Given this list of marker genes PPP1CB, GPC6, WRAP73, LGI2, ACAN, KIF5C, MBNL3 (muscleblind like splicing regulator 3), OLFM3, PITPNC1, GALNT16, NAB1, DIO2, ZNF208, FERRY3, SATB2, SLC23A3, STAC, CCND2, ZNF704, RIGI, PISD (NCBI Gene Id 29838), ADCY7, RREB1, VEZF1, EPB41L1, KLHDC7A, SLC25A30, CSF2RB, GRM5, FYN, DYRK1A, FAXC, IKZF4, ACOT13, RCOR3, ZBTB34, EYA4, PDE5A, ATP1B4, TBC1D8, NECTIN1 (NCBI Gene Id 84853), STXBP4, KLKB1, TMEM108, ZBTB20, MAP7, TDRD6, DNAJC6, PLXNA4, CEP350, ETV5, PIK3C2A, ARHGAP5, TMPO, TAF4, SCAI, SKAP2, PRDM1, XKR4, CAMK1G, PTPRB, CACNA1G, ADAMTS3, MECP2, CNTN4, CTNNA3, SERPINE2, ZNF117, ANKRD27 (NCBI Gene Id 84079), ADGRG2, CKAP4, ZFP64, YIPF2 (Yip1 domain family member 2), HERC3, TXNDC17, CD44, GSE1, PRDM2, TWSG1, PFAS, AHCYL2, GABPA, KIF1B, STK40, FHIP1A, GPRC5B, COX20, ZNF99, ANKRD44, PTPN2, HBS1L, TBC1D8B, CAMK1D, KMT2A, TTR, NPAS2, ANKRD13C, CPEB2 (cytoplasmic polyadenylation element binding protein 2, NCBI Gene Id 285549), UBE4B, CNOT6L, NR1D2, L3MBTL3, NHSL3, COL5A2, IPP, NEK1, ACTN4, DPP4, RUNX1T1, ARK2N, TMEM64, MMP24, GPR158, NLRP13, RAB7B, DCC, KCTD9, PRR11, ADGRL3, BBX, RIPOR2, ZNF732, SDC2, RHOBTB1, SLC11A2, MEF2C, HLF, FMNL2 (formin like 2), JAGN1, AHCTF1, ZNF180, TNC, ZNF107, RNF19A, MICU3 (NCBI Gene Id 286097), MEIS1, NCOA2, PALMD, CBL, BRWD3, EIF2S3, TEX2, ATXN1L, BCL11A, KRT33B, ARID4A, ZNF138, MAFG, PAX6, YTHDF3, KIAA1210, OSBPL8, HUNK (NCBI Gene Id 30811), FRMPD4, MAP6D1, COMT, here is a description of the gene set: Human Gene Set: MIR1251_3P Genes predicted to be targets of miRBase v22 microRNA hsa-miR-1251-3p in miRDB v6.0 with MirTarget v4 prediction scores > 80 (high confidence targets). from publication Chen Y, Wang X (PMID 31504780) studied in species Homo sapiens